The following is a description of a gene set: studied in species Mus musculus Mouse Gene Set: GOBP_REGULATION_OF_MITOTIC_CELL_CYCLE_PHASE_TRANSITION Any process that modulates the frequency, rate or extent of mitotic cell cycle phase transition., and this is the list of marker genes: Tjp3 (NCBI Gene Id 27375), Psme1, Smarcd3, Ier3, Zfp207, Dgkz, Fbxo5, Zfp830, Cul3, Pkia, Zfp36l1, Dlg1, Lsm11, Eif4g1, Neurog1, Cdc14b, Lmnb1, Btn2a2, Sass6, Nek11, Cdkn2a, Pabir1, Ccne2, Plk3, Ube2e2, Stox1, Rdx, Anapc15, Mir124a-1, Rad17, Trex1, Actl6a, Ube2u, Lsm10, Arid1a (NCBI Gene Id 93760), Cdk3, Smarce1, Nsmce2, Tert, Cdk2, Zfyve19, Pkd2 (polycystin 2, transient receptor potential cation channel), Pinx1, Mta3, Ppp2ca, Dact1, Smarcd2, Cdk6, Ctdsp1 (CTD small phosphatase 1), Cdc23, Kank2, Dcun1d3, Trp53, Ecd, Ik, Plcb1, Gjc2 (NCBI Gene Id 216793), Clspn, Tcf3, Akt1, Bcl7c (B cell CLL/lymphoma 7C), Ttk, Hyal1, Anapc7, Dusp1, Birc5, Brd7, Anapc15-ps, Smarcc1, Cdkn1b, Ercc2, Hus1, Nabp1, Tpr, Klhl22, Incenp, Rad50 (NCBI Gene Id 19360), Spc24, Gpr132, Inip, Knl1, Cdc25c, Hacd1, Rpl17, Ino80, Xpc, Syf2, Nabp2, Anapc11, Bcl7a, Cdc73, Rpa2, Actb, Smarca2, Nbn, Larp7 (NCBI Gene Id 652994), Acvr1, AY074887, Mbtps2, Plk5, Rfwd3, Brd4, Zfp36l2, Rbbp8, Rint1, Cul4b, Dbf4, Bub1, Rbl1, Smarcc2, Ticrr, Cdc25a, Apc, Tm4sf5, Myo16, Foxo4 (NCBI Gene Id 54601), Appl2, Cdkn1c, Ccl12, E2f7, Miip, Sin3a, Tfap4, Ddb1, Atad5, Prpf4b, Khdc3, Cdc7, Prkcq, Cacnb4, Fbxo7, Egfr, E2f1, Ppp2r3d, Rb1, Cdk5rap2, Cdk5rap3, Vps4a (NCBI Gene Id 78220), Cul4a, Jade1, Ctdspl, Orc1, Cenpf (NCBI Gene Id 98315), Gigyf2, Camk2d, Arid2, Gpnmb, Mir26b, Haspin, Xrcc3, Babam1, Mad2l1, Crlf3 (cytokine receptor-like factor 3), Trip13, Rab11a, Bard1, Ctdsp2, Phf10, Creb3l1, Id2, Pkmyt1, Sde2, Rbl2, Bub3, Ska1, Klf4, Nuf2, Inhba, Usp44, Ska3, Cyp1a1, Aurkb, Trim39, Tmod3, Cdc14a, Cdk2ap2, Ints3, Chek1, Hus1b, Smarcd1, Pcid2, Anp32b, Fam107a (NCBI Gene Id 268709), Klf11, Fbxo31, Pbrm1, Mtbp, Spc25, Bcl2, Mir26a-2, Hecw2, Mre11a, Chmp4c, Cpsf3, Foxn3, Kmt2e, Pten, Gen1, Anapc5, Atm, Smarcb1, Mad2l1bp, Dync1li1, Brca1, Ambra1, Zw10, Cenpe, Taok2, Mdm2, Pkd1, Kcnh5, Crebbp, Brcc3dc, Riok2, Usp47, Cdk4, Ndc80, Babam2, Wee1, Ubd, Cdc6, Kntc1, Ccnd2, Rad21, Ankrd17, Mir124a-2, Fzr1, Rgcc, Brcc3, Cdkn2b, Npm2, Mepce, Rad51c, Cdc16, Nek6, Tgfb1, Ptprv, Cdc25b, Mblac1, Rps27l, Fgf10 (NCBI Gene Id 14165), Mbd4 (methyl-CpG binding domain protein 4), Fhl1, Kcna5, Aven, Pbx1, Plk1, Rnaseh2b, Ccnd3, Wnt10b (NCBI Gene Id 22410), Mir124a-3, Kif14, Mir26a-1, Ccnd1, Tpra1, Hspa2, Rrm2b, Lcmt1, Rcc2 (regulator of chromosome condensation 2), D7Ertd443e, Brsk1, Slfn1, Ctc1, Ezh2, Ube2c, Mrnip, Anapc4, Anxa1, Mbtps1, Ddx3x, Psme3, Tfdp1, Dpf1, Uimc1 (ubiquitin interaction motif containing 1), Appl1, Wac (WW domain containing adaptor with coiled-coil), Cdk1, Cdca5, Pdpn, Bub1b, Prkdc, Actl6b, Chfr, Ddr2, Ccng1, Bid, Taok1, Abraxas1, Ccnh, Smarca4, Arhgap33os, Etaa1, Adam17 (NCBI Gene Id 236174), Psmg2, Mad1l1, Cdca8, Blm, Cdkn2c, Plrg1, Mnat1, Cep192, Pdik1l, Men1, Stk35 (NCBI Gene Id 67333), Rrm1, Dpf2, Atr, Cdc20, Ccnb1-ps, Tex14, Vps4b, Cenpj, Topbp1, Dpf3, Zwint, Stil, Apex1, Zc3h12d, Phb2, Nop53, Cdkn2d, Donson, Bcl7b, Ccnb1, App, Ercc3, Cdk7, Senp2, Zfp655, Ccne1, Ptpn6, Taok3, Spdl1, Psme2, Rptor, Adamts1, Nae1, Rrm2, Dtl, Cdkn1a, Aif1, D1Pas1, Prmt2, Zwilch, Rad51b, Klhl18, Prap1